The following is a description of a gene set: The process in which a relatively unspecialized monocyte acquires the specialized features of a macrophage. species: Homo sapiens Human Gene Set: GOBP_MACROPHAGE_DIFFERENTIATION, and this is the list of marker genes: CEBPA, SIRT1, PRKCA, CSF1, TLR2, ID2, CD4, TLR4, LARGE1, CALCA, UCP2, IGHE, C1QC, NPM1, NRROS, INHA, TAOK3, TSPAN2, NDP, IL1RL1, NKX2-3, ZBTB46, RB1 (NCBI Gene Id 92728), ADIPOQ (adiponectin, C1Q and collagen domain containing), IL34 (interleukin 34), APP, CSF2, CCDC39, GBA1, VPS13A, IL31RA, VEGFA, VPS54, DIAPH3, EIF2AK1, CASP8, HSF1, SOCS1, INHBA, SPIB, PTPN2, PF4, MIR486-1, LIF, CEBPE, NAGLU, PARP1, GAB3, FOSL2, GATA3, IL15, ARID3C, BMP4, IL33, MMP9, MIR145, CSF1R, RIPK1, MYD88, L3MBTL3, CFLAR, CDC42, HLA-DRB1, HCLS1, MFSD8, MIR223, FADD, NR3C1, GATA2, QKI, IFNG, TRIB1, SPI1, TGFB1